Given this list of marker genes SLC26A2, PEX14, GRM7 (glutamate metabotropic receptor 7), TSFM, DYNLT2B, PHOX2B, SMO, ALG1, ALG14, ALG8, FARS2, PRPS1, PIK3CA, CRTAP, ACOX1, CRLF1, RAD51C, NSF, MESP2, RPL3L, SLC25A19, BOLA3, ACAD9, ACADVL, ATP6AP1, ECHS1, PQBP1, NDUFAF3, ITGB4, FGG, SLC25A46, QRSL1, DNM2, VPS35L, TTC7A, ACTG2, POMT2, NFS1, LTBP4, AFF3, PIGB, PLEC, FAM111A, TSEN54, DNM1L, PMM2, TRMU, TRIP11, DCX, EFL1, LTC4S, SCYL2, DHCR7, SCO2, AARS2, SMOC1, VPS33B, PIGY, FGA, NADK2, STX3, HESX1 (HESX homeobox 1), COX10 (cytochrome c oxidase assembly factor heme A:farnesyltransferase COX10), MRPS34, ITPA, FANCB, EPCAM, CPT2, AIMP1, LHX4, COX16, TUFM (Tu translation elongation factor, mitochondrial), DLL3, PEX10, RBM8A, GDF5, SFTPB, PLVAP, LAMA3, PET100, CLCF1, PPCS, SLC25A4, ERCC5, SMPD4, PSAP, HTRA2, PEX3, VIPAS39, ORC1, C2orf69, IKBKB, UBR1, SMARCD2, GLB1, MYO5B, LRPPRC (leucine rich pentatricopeptide repeat containing), KRT5, ALPL, AP1S1, RNU4ATAC, PEX12, SNRPB, PEX16, PIGA, DPH1, NUP214, NDUFV2, LAT, ROR2, LAMB3, MSH6, ERCC6, NPC2, LAMC2, TPI1, RET, LMOD3, NR1H4, MBTPS2, TOR1A, ROBO1, LIPA, EPG5, JAM3, BMPR1B, FGFR3, FRAS1, ATP1A2, FLI1 (Fli-1 proto-oncogene, ETS transcription factor), HSPG2, CDON, ADCY6, PEX13, EXTL3, MYLK, GATC, PEX2, TRMT10C, WT1, COG7, GBA1, PEX26, SUCLG1, ASXL3 (NCBI Gene Id 80816), PMS1, GPC3, DPM2, LMOD1, SUOX, TSEN2, PAM16, CCDC22, STAT2, BRAT1, MLH1, ERCC1, COX5A, RMND1, GLDC, FGB, MRPS22, CRPPA, ATRX, PEX11B, ARX, PEX5, HADHB, PLXND1, TMEM70, CRYAB (crystallin alpha B), LIPT2, TFAM, CRLS1, OCRL, KIF20A, COX11, GFAP, PTF1A, SCN4A (NCBI Gene Id 6329), ERCC2, FXR1, AIMP2, KLHL40, ASCL1, MADD, PSAT1, GPC4, DOLK, EMG1, PROKR2 (NCBI Gene Id 3733), ANTXR2, MPDU1, TNFRSF11A, LIFR, PEX1, ELAC2 (elaC ribonuclease Z 2), SIK1, LMNA, SLC25A24, TGFBR2, TSPYL1, DPYSL5, OAS1, CRIPT, MSH2, ABCA3, PEX19, WASHC5, MYL1, NRAS, CDC40, WDR11 (WD repeat domain 11), REV3L, GRIP1, ZNFX1, NDUFA2, NFU1, ABCA12, COASY, GPR161, PEX6, CD96, MRPL44, ACTA1, HDAC6, KRAS, MYH11, ORAI1, ETHE1, CD3G, FREM2, PPIL1, NXN, NDUFS4, MYL2, TMEM260 (transmembrane protein 260), JPH2, NEB, NADSYN1, IDUA, CDK5, COG6, FAM20C (FAM20C golgi associated secretory pathway kinase), CNTN1, LIPT1 (lipoyltransferase 1), DPH5, PMS2, here is a description of the gene set: Death in infancy Death within the first 24 months of life. species: Homo sapiens Human Gene Set: HP_DEATH_IN_INFANCY